Given this list of marker genes Il6st, Rubcn, Flt1, Zfp180, Ddx3x, Rbpj, Mterf2, Tram1, Commd2, Sptlc1 (serine palmitoyltransferase, long chain base subunit 1), Vldlr, Olfm3, Vwde, B3gat2, Ddhd1, Mink1, Nhsl3, Ism2, Rarb, Sema6d, Asf1b, Snx8, Atad2, Mtmr3, Nkain3, Kcnb1, Pde3b, Rock2, Srd5a1, Nudt12, Irf2, Ubap1, Aebp2, Wnt9b, Nfib, Unkl, Gpr137b, Caprin2, Ctcfl, Map3k2, Dapp1, Ankrd52, Tmem38b, Creb5, Vsx1 (visual system homeobox 1), Med12l, Pak5, Lefty2, Yod1, Slc6a9, Slc16a9, Qser1, Ankrd17, Arid4b, Fign, Rab33b, Clock, Tnfaip1, C1qa, Tmub2, Atp2b2, Zfp804a, App, Rgs13, Prdm8, Tom1l2, Tgfbr2, Ss18l1, Lmo3, Slc22a20, Vash2, Ube2q2, Map3k14, Pigm, Lhcgr, Lif, Rbl1, Lhx6, Polk, Vamp3, Slc24a3, Crot, Rac1, Cdh4, Slc25a40, Ralgps2, Glis3, Gab3 (NCBI Gene Id 353202), Rasal2, Pou4f1 (NCBI Gene Id 78006), Fktn, Pip4k2a, Adamtsl3, Mex3a, Mtf1, Mnt, Cfl2, Rab11a, Ednrb, Kmt2e, Cyp26b1, Usp24, Nol7, St6galnac6, Cdk19, Pcdh7, Wnt5a, Septin2, Osbpl8, Marchf5, Cxxc5, C1ra, Picalm (phosphatidylinositol binding clathrin assembly protein), Dync1li2, Arpp21, Rb1cc1, Rfx7, Rassf2, Prc1, Tfap4, Pkn2, Armc8, Dlg3, Slc38a2, Lrba, Fabp9, Col17a1, Jazf1, Arid4a, Cd109, Slc22a23, Ythdf3, Fyco1, Derl2, Slco3a1, Esr1, Zfp800, Nfkbie, Mdga2, Rnf150, Plag1, Adamts18, Spred1, Tmtc1, Epc1, Kmt2a (NCBI Gene Id 214162), Prdm4, Tet1, Zfp654, Avil, Sar1b, Cdkn1b, Fgd5, Zbtb11 (zinc finger and BTB domain containing 11), Mbnl2, Edn3, Itfg1, Camsap1, Baz1a, Ppp1r3e, Exph5, Zbtb41, here is a description of the gene set: studied in species Mus musculus Genes predicted to be targets of miRBase v22 microRNA mmu_miR_302c_3p in miRDB v6.0 with MirTarget v4 prediction scores > 80 (high confidence targets). Mouse Gene Set: MIR_302C_3P from publication Chen Y, Wang X (PMID 31504780)